Given this list of marker genes ACVR1, FANCI, ENPP1, AFF4, DCC, NOG (noggin), PLOD2 (procollagen-lysine,2-oxoglutarate 5-dioxygenase 2), CHD4, GDF3, CHRNG, MEOX1, SALL4, GDF6 (NCBI Gene Id 9571), RAD51, DNAL4, COL2A1, MAP3K7, TBX5, RBM8A, MYH3, FGFR2, CDH11, ASXL2, DKK1, FLNA, WBP11, AEBP1, NTN1, PUF60, IL1RN, BRPF1, FLNB, MYO18B, ASH1L, ABCC6, here is a description of the gene set: species: Homo sapiens Human Gene Set: HP_FUSED_CERVICAL_VERTEBRAE A congenital anomaly characterized by a joining (fusion) of two or more cervical vertebral bodies with one another. Fused cervical vertebrae